The following is a description of a gene set: studied in species Homo sapiens An increased level of gamma globulin (immunoglobulin) in the blood. Human Gene Set: HP_INCREASED_CIRCULATING_IMMUNOGLOBULIN_CONCENTRATION Increased circulating immunoglobulin concentration, and this is the list of marker genes: ELANE, GPR35, FOXP3, DOCK8, KRAS, NRAS, MYD88, SLC7A7, POMP, IRF5, CD40LG, TCF4, TGFB1, CDSN, IL2RA, IL21, IFNGR1, SLC19A1, SETX, ADA, RASGRP1, TERT, SPINK5, IL7R, EGFR, GPC3, NFKBIA, NCKAP1L, OTULIN (OTU deubiquitinase with linear linkage specificity), EXTL3, COL1A1, PSTPIP1, SFTPC, KLHDC8B, CD3D, SEC61A1, IL2RG, VPS33A, MMEL1, STAT5B, IKBKG, IL6ST, CASP10, MST1, DSG1, AICDA, DCLRE1C, PDCD1, VPS45, STAT6, IL2RB, GPC4, PSMB4, FASLG, SCARB2, ARPC5, ADAM17, FAS, GTF2H5, TYK2, TNPO3, PIK3R1, SEMA4D, UNG (uracil DNA glycosylase), COL7A1, IPO8, DOCK11, PGM3, NSMCE3, IL12RB1, POU2AF1, GBA1, PEPD, TNFSF15, KRT74, POLD3, PIK3CD, STIM1, SPPL2A, DNMT3B, STAT3, IFIH1, CARD11, CD40, CD247, LIG4, IRAK4, NLRP1, WAS (WASP actin nucleation promoting factor), DRG1, SH2D1A, MVK, CARD10 (caspase recruitment domain family member 10), ALB, PTEN, IRF1, HLA-DRB1, MUC5B, CARD9, CD3E, ZNF341, KRT9, PSMB8, PRKCD, TPP2, CCND1, STING1, IL12A, IL6R, SPIB, SFTPA2, XIAP